Given this list of marker genes ALDH3A1, SLC47A2, MFAP4, RNF112, ALDH3A2, B9D1, MAPK7, EPN2, SLC47A1 (NCBI Gene Id 55244), ULK2, here is a description of the gene set: species: Homo sapiens Genes within amplicon 17p11 identified in a copy number alterations study of 191 breast tumor samples. from publication Nikolsky Y, Sviridov E, Yao J, Dosymbekov D, Ustyansky V, Kaznacheev V, Dezso Z, Mulvey L, Macconaill LE, Winckler W, Serebryiskaya T, Nikolskaya T, Polyak K (PMID 19010930) A single cancer cell contains large numbers of genetic alterations that in combination create the malignant phenotype. However, whether amplified and mutated genes form functional and physical interaction networks that could explain the selection for cells with combined alterations is unknown. To investigate this issue, we characterized copy number alterations in 191 breast tumors using dense single nucleotide polymorphism arrays and identified genes with copy number gain organized into 30 amplicons. Amplicons were distributed unequally throughout the genome. Each amplicon had distinct enrichment pattern in pathways, networks, and molecular functions, but genes within individual amplicons did not form coherent functional units. Genes in amplicons included all major tumorigenic pathways and were highly enriched in breast cancer-causative genes. In contrast, genes with somatic mutations in breast cancer were distributed randomly over the genome, did not represent a functionally cohesive gene set, and were relatively less enriched in breast cancer marker genes. Mutated and gained genes did not show statistically significant overlap but were highly synergistic in populating key tumorigenic pathways including transforming growth factor beta, WNT, fibroblast growth factor, and PIP3 signaling. In general, mutated genes were more frequently upstream of gained genes in transcription regulation signaling than vice versa, suggesting that mutated genes are mainly regulators, whereas gained genes are mostly regulated. ESR1 was the major transcription factor regulating amplified but not mutated genes. Our results support the hypothesis that multiple genetic events, including copy number gains and somatic mutations, are necessary for establishing the malignant cell phenotype. Human Gene Set: NIKOLSKY_BREAST_CANCER_17P11_AMPLICON